Given this list of marker genes MFHAS1, ACOD1, TNFAIP3, TLR6, TREM2 (triggering receptor expressed on myeloid cells 2), LYN, here is a description of the gene set: Human Gene Set: GOBP_NEGATIVE_REGULATION_OF_TOLL_LIKE_RECEPTOR_2_SIGNALING_PATHWAY species: Homo sapiens Any process that stops, prevents, or reduces the frequency, rate, or extent of toll-like receptor 2 signaling pathway.